The following is a description of a gene set: Genes down-regulated in comparison of early germinal center (GC) B cells versus late GC B cells. from publication Wilke G, Steinhauser G, Grün J, Berek C (PMID 20518031) Upon immunization with a T cell dependent antigen naive follicular B cells (Fo) are activated and a germinal center reaction is induced. Within the next 2 weeks large germinal centers develop where the process of affinity maturation takes place. To analyze the gene expression profile of resting and activated B cells, follicular B cells (Fo), B cells from early (GC1) and late germinal centers (GC2) were isolated and their gene expression profile compared. studied in species Homo sapiens Human Gene Set: GSE28237_EARLY_VS_LATE_GC_BCELL_DN, and this is the list of marker genes: NIBAN2, PRKAB1, SCN1A, RPL12 (ribosomal protein L12), PARP3, AIP, PPP1R11, PRR14 (proline rich 14), PUS3, SERF2, CROCC, THOC1, REPS1, TCF3, MPP1, FCGR2A, AK3, CPLANE2, PIGO, MAPKAPK5, SLC16A6, EPC1, CCM2, TTC39B, RRBP1, RPS27, ABTB2, XRN2, ANGPT1, KCNJ8, GLIPR1, STAT6, RNF217, MYO1G, MYH8, TAPBP, PKP4, MRPL30, MYORG, LAMTOR1, TECR, NLK, GRAMD1A, HECTD3, PHYKPL, EN1, SMIM14, CDK16, PLCL2, PPA2, DNAJC1, SLC35A2, WASHC2A, VSIR, SUPT20H, PRR12, DDX18, PBXIP1 (NCBI Gene Id 57326), KDM1A, TNFRSF17, WASF2, RNPEPL1, PHPT1, SAFB, RPRD2 (regulation of nuclear pre-mRNA domain containing 2), NAPSA, RPL39, MIA3, BCL7B, KLF12, CD48, SELENOP, RAB3GAP2, ARMC7, KDM3B, NHERF1, DAPK2, MAP4K1, GFUS, PLCL1, FBXW4, KLRK1, MYO18B, INSYN2B, KCTD4, IGKC, MSS51, IFT56, CPT2, TJP2, NCBP2AS2, SASH3, G0S2, C4orf36, SPEN, NSFL1C, HOXA2, CHSY1, AHCYL1, METTL3, DDX23, LIMK1, KIAA2013, MAGEL2, ARHGEF7, TPD52L2, TRAPPC12, RPL23A, RPL23, ABR, B3GAT3, TBRG1, CHPF, TMEM87A, SEMA4A, DGKZ, INSM2, TMEM222, ACP3, CSF1R, PSD2, FAM124B, UBXN4, RDH14, GZMB, ICA1, SURF1, PREX2, LRP10, BHLHE40, YTHDF1, PREX1, FOXI1, CAST, PEAR1, PLCE1, KCNAB2, DUS3L, DSP, APOBEC3B, RHOC, TAX1BP3 (Tax1 binding protein 3), MINDY2, OTUD5, SVBP, APCDD1, SSBP1, KLHL4, SNX15, NFE2L2, ZNF319, AGTRAP, PTPRCAP, GNMT, RING1, PEA15, PNPLA2, ATP10A, ZFAND3, RIOK1 (RIO kinase 1), MED13L, PPM1J, ALKBH4, NEU2, LIMD1 (NCBI Gene Id 8994), PLEC, TBC1D10C, VASP, PHF21A, DPH1, FLII, SACM1L, ADSL, TSPO, SRPRA, ACSS2, PRODH2, PSME2, EVL, ANXA2, HSD17B4, ASPDH (aspartate dehydrogenase domain containing), ATP13A1, MGAT5, YWHAB, RNF6, ATP6V0B, CCDC97, TMEM86B, POGK, GALNT6, AQR, LZTR1, TNK2, DIAPH2, SLC12A4, MAP2K7, PUM3, MYH9, NR4A2